Given this list of marker genes CYFIP2, MAPK1, IGLV7-43, IGLV2-11 (immunoglobulin lambda variable 2-11), RAC1, PTK2, IGLV1-51, ARPC5, BAIAP2, VAV2, MAPK3, WIPF3, IGHV4-59, IGHV3-30, IGHG4, WASF2, IGKV3-11, IGLV2-8, NCKIPSD, IGKV3D-20, IGKV1-16, ELMO2, NCKAP1, IGKV1D-39, HCK, WIPF1, GRB2, YES1, CDC42, IGKV1-5, ARPC1A, IGHV1-69, IGKV2-30, WASL, FYN, NCKAP1L, ELMO1, IGLV3-25, IGHG1, ACTB, IGHV3-7, IGKV1D-12, NCK1, IGHV3-11, SRC, ABI1, ABI2, CRK, IGKV1-39, IGKV3-20, WIPF2, IGHV3-33, IGKV2-28, SYK, IGLV3-1, IGLV3-19, IGKV5-2, IGHV3-13, VAV1, ACTR2, ARPC3, MYO5A, IGLV2-14, WASF3, ARPC2, MYO10, IGLV3-27, IGHV3-23, IGLV1-40, ARPC1B, IGKV3-15, IGLC2, ACTG1, ABL1 (NCBI Gene Id 25), IGLC3, WAS, IGKV2D-30, BRK1, IGKV1-33, IGKV1D-16, WASF1, CYFIP1, ACTR3, IGHV4-34, CD3G, IGHG2 (immunoglobulin heavy constant gamma 2 (G2m marker)), VAV3, IGHV2-5, IGLV3-21, IGKV2D-28, ARPC4, IGHV4-39, BTK, LYN, MYO1C, IGKV2D-40 (immunoglobulin kappa variable 2D-40), MYH9, IGLV1-47, IGHV1-46, IGHV3-48, IGLV2-23, FCGR3A, IGKV1D-33 (immunoglobulin kappa variable 1D-33), DOCK1, CD247, FGR, IGHV3-53, IGHV2-70 (NCBI Gene Id 649805), IGKV1-12, IGKV1-17, IGLV6-57, MYH2, MYO9B, IGHV1-2, IGLV1-44, IGKV4-1, here is a description of the gene set: Parasite infection species: Homo sapiens Human Gene Set: REACTOME_PARASITE_INFECTION